Given this list of marker genes SLC38A2 (solute carrier family 38 member 2), ABAT, SLC25A15, TENM2, COL4A1, USP32, MECP2, ASCL1, C1orf52, PPP1R12B, GLG1, OSBPL11, SPOPL, PCDH17, MMD2, ATF7IP2, ITGAD, HNRNPDL, RAB10 (RAB10, member RAS oncogene family), KCNQ3, ASPN, PAPOLG (NCBI Gene Id 64895), PSMA4, PALLD, BHMT2, CDCP1, HSPH1, TRIM41, SORCS1, CDCA7L, MAST4, USP6, MYOCD, BCL2L1, PPP1R3D, LGALSL, ZEB2, PTPN5, GSPT2, SIGLEC6, USP49, CDK6, ZBTB34, SCN1A, TP73, KCNS2, EVPL, FBXW7, AAK1, PITPNM3, TBC1D16, TGS1 (NCBI Gene Id 96764, trimethylguanosine synthase 1), LRP6, KISS1R, RAPH1, PCDHB7, CCNL2, PIM3, NFIB, H2BC21, VIPAS39, NEDD4L, OGA, C21orf91, HBB, PLEKHA8, CD46, PGR, WWC3, BBOF1, PSMA3, PRSS55, PGK2, KIF2B, SPIN3, TTC19, IPMK, RHEB, GIGYF2, POLR2C (NCBI Gene Id 5432), SOX3, BMPR2, ELAVL1, SMPD3, CLINT1, HS6ST2, DIXDC1, A1CF, PGBD5, TNS1, GRB2, here is a description of the gene set: Genes predicted to be targets of miRBase v22 microRNA hsa-miR-4520-3p in miRDB v6.0 with MirTarget v4 prediction scores > 80 (high confidence targets). from publication Chen Y, Wang X (PMID 31504780) Human Gene Set: MIR4520_3P studied in species Homo sapiens